The following is a description of a gene set: Any protein complex that is part of the plasma membrane and which functions as a signaling receptor. Mouse Gene Set: GOCC_PLASMA_MEMBRANE_SIGNALING_RECEPTOR_COMPLEX species: Mus musculus, and this is the list of marker genes: Traf2, Drd1, Cntfr, Itgb7, Shisa7, Vwc2l, Igkc, Abhd12, Gabbr2 (NCBI Gene Id 279273), Vwc2, Itga5, Tgfbr1, Jak2, Gria3, Il6st, Itgad, Cd3e, Grik2, Cd79b, Cacng4, Itgb4, Sdcbp, Chrnb2, Chrnb1, Eps8 (NCBI Gene Id 13860), Itgam, Itgal, Hjv, Itgb6, Gria4, Olfm1 (olfactomedin 1), Ighd, Cd247 (NCBI Gene Id 98717), Lrrtm4, Itgax, Tlr2, Sacm1l, Igf1r (NCBI Gene Id 77773), Lyn, Tlr6, Itga7, Tgfbr2, Il23r, Cd79a, Itga10, Chrna5, Trbc1, Grik5, Tlr1, Dlg4, Diablo, Itgb1, Ceacam2, Itgb2l, Stxbp5, Ikbkb, Csf2rb (NCBI Gene Id 12983), Chrna1, Itga4, Gp1ba (glycoprotein 1b, alpha polypeptide), Gp5, Plp1, Grin2d, Grik1, Chrnb3, Cpt1c, Grin3a, Chrna7, Chrne (NCBI Gene Id 11448), Grin2a, Gp1bb, Acvr2a, Syk, Itga8, Tyk2, B2m, Cacng3, Itga6, Ighe, Trbc2, Cd40, Erbb3, Skap1, Ramp1, Ticam2, Itga11, Il6ra, Acvr1 (activin A receptor, type 1), Cd3g (CD3 antigen, gamma polypeptide), Il18rap, Shisa8, Cnih2, Abhd6, Itga2, Ifnl2, Cacng5, Insrr, Acvr2b, Dlg3, Traf6, Itgbl1, Tfrc, Apbb1ip, Chrna3, Gria1, Grin2c, Porcn, Il12rb1 (NCBI Gene Id 270057), Ighm, Ceacam1, Traf5, Gria2, Nrn1, Itgb3, Birc2 (NCBI Gene Id 77616), Trav18, Gpr156, Acvr1c, Itgb2, Zap70, Chrna2, Emilin1, Htr3b, Trat1, Chrna9, Grid2, Ptpn6, Gp9, Itgb5, Csf2rb2, Cacng2, Ramp2, Tspan32, Itga2b, Grik3, Trf, Alcam, Itga9, Tfr2, Cacng7, Itgb8, Htr3a, Chrnb4, Chuk, Hfe, Gabbr1, Ptk2b, Il18r1, Drd2, Erbb2, Calcrl (calcitonin receptor-like), Grik4, Insr, Trbv19, Trac, Shisa9, Cacng8, Ifnl3 (NCBI Gene Id 338374), Calcr, Itgae, Bmp2, Grm1 (NCBI Gene Id 74875, glutamate receptor, metabotropic 1), Cd3d, Cd6, Ramp3, Itgav, Shisa6, Grin2b, Flna, Acvr1b, Csf2ra, Htra2 (HtrA serine peptidase 2), Grin3b, Olfm3, Acvrl1, Chrnd, Chrna4, Rnf31, Lime1, Olfm2, Iglc1, Irs1, Il6, Traf3, Cnih3, Osmr, Itga1, Grin1, Grid1, Pmp22, Chrna6, Chrng, Ifnlr1, Itga3, Csf2